The following is a description of a gene set: Human Gene Set: GOCC_INHIBITORY_SYNAPSE A synapse in which an action potential in the presynaptic cell reduces the probability of an action potential occurring in the postsynaptic cell. species: Homo sapiens, and this is the list of marker genes: GAD1, SLC32A1, IGSF21, SYT11, LHFPL4, IQSEC3, GPHN, NLGN4X, GIT1, NLGN4Y, NLGN2, GABRA2, MAF1, IGSF9, DTNB, CEP112, GLRA1 (glycine receptor alpha 1), NLGN3